Given this list of marker genes KCNT1, RELN, CHRNA4, CABP4, NACC1, NPRL3, CRH, GLRA1, GPHN, SPTBN1, SATB1, CHRNB2, NPRL2, KCNN2, CHRNA2 (NCBI Gene Id 1135), DEPDC5, LGI1, GRIN2A, here is a description of the gene set: species: Homo sapiens Human Gene Set: HP_NOCTURNAL_SEIZURES Nocturnal seizures Seizures that occur while the affected individual is sleeping.